The following is a description of a gene set: from publication Lang R, Pauleau AL, Parganas E, Takahashi Y, Mages J, Ihle JN, Rutschman R, Murray PJ (PMID 12754506) Human Gene Set: GSE411_100MIN_VS_400MIN_IL6_STIM_MACROPHAGE_DN studied in species Homo sapiens Effects of SOCS3 on the transcriptional response of bone marrow-derived macrophages to IL-6. Fetal liver cells from SOCS3+/+ or SOCS3-/- embryos were used to reconstitute recipient mice. Donor derived bone marrow from these mice was differentiated to macrophages. Macrophages were either unstimulated, or stimulated for 100 or 400 minutes with 10 ng/ml IL-6. Genes down-regulated in macrophages treated by IL6: 100min versus 400min., and this is the list of marker genes: SUPT3H, LPIN1, GCLC, RIOX2, EEF1G (eukaryotic translation elongation factor 1 gamma), ABCE1, NSFL1C, RCC1, NOL8, PRMT6, THOP1, NOP9 (NOP9 nucleolar protein), SOD1, POLR1F, NAF1, MYO1E, WDR55 (NCBI Gene Id 54853), PFDN6 (NCBI Gene Id 10471), NAA50, TAF1D, DYNLL2, LYAR, MIF, NR4A2, QTRT1, IFRD2 (interferon related developmental regulator 2), GEMIN6, UTP18, CINP, HPGDS, PMEPA1, PSMD7, NHP2, NDUFB6, DPAGT1, RWDD1, SLC1A5, CCDC90B, SPG21, ALG8, MARCKS, BABAM2, ZNRD2, HPRT1, FAM162A, ILF3, SLC29A2, CD320, DDX1, CAMSAP1, ALG5, SLC25A6, BANF1, MTHFD1L, KIF2A, MRPS22, ATP5MC3, HAX1 (HCLS1 associated protein X-1), ADH5, ABRACL, ATIC, IPO7, SIMC1, NMNAT3, E2F6, PRDX6, FAM185A, CCDC115, TMEM165, WEE1, ZIC2, PSMA3, SNRPD1, ADORA2A, SLC39A14, CLUH, NDUFA12, PSMA4, GOT1, CNOT9, NAA15, SEPTIN11, SNHG12, NINJ1, PHB1, PSMB6, SERBP1, FAM133B, TTI2, DUS4L, RAD23A, OTUD4, CREG1, ACTN1, GLRX5, SURF2, MAGOHB, WDR77, MYOZ2, RPL7L1, JMY, SUGT1, AHSA1, BTF3L4, FBXO11, TRMT61A, CLPP, TIGAR, GLA, MYO19, NPM1, TFDP1, ALG3, KRAS, METAP2, SMN1, CCDC43, TBL3, GEMIN5, NEFH, EIF5B, DOT1L, SLC3A2, PECR, ZNF593, TOMM20, PRELID3B, PRPF31, PDCD5 (NCBI Gene Id 9141), KPNA1, ARL5B, RSL24D1, XPOT, POP1, ALDH18A1, PIGU, GFER, ADK, GTSE1, DHX33, NUP205, TGIF2, CEP170B, CALU, CFAP298, ABHD14A, HNRNPC, SLC7A1, ITSN1, GSR, POLR1C, KDM2B, GNPNAT1, PPIA, POGK, AHCYL2, WDR43, CERS6, KMT5A, PPIG, PPHLN1, ST6GALNAC2, KSR1, GCLM, KRR1, NFKBIE, LSM2, MFSD12, METTL1, FASTKD1, AHCY, HIRIP3, OLA1, YBEY, TMTC4, RIOK2, DCTPP1, MRPL3, PLSCR1, PRPF40B, MAK16, DNAJB9, AIMP2, TPI1 (triosephosphate isomerase 1), YTHDF2, SYNCRIP, HINT1, SSR4, NDUFAB1, CCDC38, MDN1, SLCO4A1, MVD, WDR70, HDGF, TRIB3, COPS6, PPP1R14B, TIMM10, GID4